Given this list of marker genes POLR3C, RNF126, ANPEP, NCKAP1, ADAM8, TCERG1, PLP2, TFAP4, ALDH1B1 (NCBI Gene Id 219), KDM2A, ICMT, ATP1B3, GAB1, AVL9, RNASE4, IGFBP7 (insulin like growth factor binding protein 7), AQP9, IL1R2, ALDH1A2, IMPDH2, ORC4, ZZEF1, XCL2, MIF, TELO2, MSH6 (mutS homolog 6), DHFRP3, SOCS1, NUP58, IER2, B4GALT2, ITGB3BP, HOMER1, GLIPR1, NFKB1, GALT, IMPA2, PGM1, ABCC6, PPBPP2, MT1G, POLR2H, HEG1, MAGEB2, TRIM28, ATXN3, PTGER3, VCAN, FAM153A, CXCL8, ZAP70, RGS16, MCM7, PLS3, PLA2R1, CDKN1C, SPINT3, BTG1, ASTN1, ACOT7, CRIP1, PDPN, HSF2, CCN1 (cellular communication network factor 1), CD83, RASSF1, MT2A, IDH2, ARFIP2, ID3, REL, GAL, ANXA1, SLC39A14 (solute carrier family 39 member 14), GLUL, MMP1, PSMC3IP, DNAH7, SDCBP, SLC5A3 (solute carrier family 5 member 3), PPFIA3, PDPK1, PRELP (NCBI Gene Id 5549), TUBB7P, H2AZ2, SDS, DPY19L1, KALRN, PDK1, CD1C, MSH2, GPX7, H4C2, PFKFB1, SNRPA, PTMS, SSRP1, ZNF292, SLC43A1 (solute carrier family 43 member 1), FOSL2, S100A10, CLOCK, MCM2, BCAS2 (BCAS2 pre-mRNA processing factor), CCR7, HLX, RCAN1, RCN2, PCLAF, ANK1, CFAP410, KHDRBS3, EGR3, SRGN, CPA1, EEF1B2, RRAS2, HRAS, MARCKSL1, SLC12A4, SLC28A2, RUSC1, IL7R, TPD52, TOMM34, CTNNB1, TPM4, MISP, P4HA2, SLC26A10P, TYMS, TRIP6, PNP, UBE2N, MT1X, TM9SF1, TGFBI, CDKL1, PFDN1, MEN1, SERPINH1, MZF1, ZNF593, GPR183, DUSP4, UCK2, LAMP3, TIMP3, MPHOSPH8, ATP2A2, GOLGA8A, PFKP, TLX1, MCM5, CYB561, BMERB1, SATB1, LPAR2, BMP6, GNA11, KLF4, ACE, GSK3B, SPR, CYC1, TNFRSF9, HMG20B, KBTBD11, HSPD1, BAAT, CH25H, GUCA1B, PDE4B, ADSS2, PTGER2, SIVA1, NFATC2IP, SRM, EIF3B, SYN2, SLC25A1, NDUFB6, MED13L, BYSL, PIK3R3, SLC2A3, MAP3K14, GADD45A, MT1B, PLOD2, MBD3, LAPTM4B, ASMTL, PPM1B, RPS6KA5, CXCL11, FAM131A, RUVBL2, SLC35D1 (solute carrier family 35 member D1), here is a description of the gene set: from publication Chaussabel D, Semnani RT, McDowell MA, Sacks D, Sher A, Nutman TB (PMID 12663451) Human Gene Set: GSE360_T_GONDII_VS_B_MALAYI_HIGH_DOSE_MAC_UP Genes up-regulated in comparison of macrophages exposed to T. gondii versus macrophages exposed to 50 worms/well B. malayi. Monocyte-derived dendritic cells (DC) and macrophages (MΦ) generated in vitro from the same individual blood donors were exposed to five different pathogens, and gene expression profiles were assessed by microarray analysis. Responses to Mycobacterium tuberculosis and to phylogenetically distinct protozoan (Leishmania major, L. donovani, Toxoplasma gondii) and helminth (Brugia malayi) parasites were examined, each of which produces chronic infections in humans yet vary considerably in the nature of the immune responses they trigger. species: Homo sapiens